Given this list of marker genes FOXE1, KAT6B, NKX2-1, NKX2-5, TSHR, SLC26A4, PAX8, here is a description of the gene set: Thyroid agenesis The congenital absence of the thyroid gland. Human Gene Set: HP_THYROID_AGENESIS studied in species Homo sapiens